The following is a description of a gene set: Human Gene Set: MIR1237_5P_MIR4488 from publication Chen Y, Wang X (PMID 31504780) species: Homo sapiens Genes predicted to be targets of miRBase v22 microRNA hsa-miR-1237-5p, hsa-miR-4488 in miRDB v6.0 with MirTarget v4 prediction scores > 80 (high confidence targets)., and this is the list of marker genes: SLC8A2, MDGA1, CARMIL1 (capping protein regulator and myosin 1 linker 1), SCRT1, NAT8L, ADGRL1, IQSEC2, NFIX, RLBP1, EFNB1, IGF2, FOXP4, PDGFB, MELTF, HPD, NFIC, WNT1